Given this list of marker genes NR5A2, TAF4, FANCG, DMC1, NPPC, INHA, ZNF830, VGF, SOD1, LSM14B, EIF2B4, MMP19 (matrix metallopeptidase 19), FSHB (NCBI Gene Id 2488), FOXL2, BMPR1B, UBE3A, FOXO3 (forkhead box O3), SMAD4, ATM, GPR149, CGA, ZP3, BCL2, SCAPER, UMODL1, EIF2B5, ANG, EREG, LFNG, CTNNA1, AMH, FANCE, CEBPB, MSH4 (mutS homolog 4), FOXC1, IMMP2L, SPO11, MMP14, GNRH1, INHBB, KIT, KDR, ESR1, TNFAIP6, MMP2, FSHR (NCBI Gene Id 4959), GAS2, INHBA, PTX3, RAC1, PCYT1B, ZFY (zinc finger protein Y-linked), LHCGR, DMRTA1, HYAL3 (NCBI Gene Id 8372), KITLG, BAX, EIF2B2, BCL2L1, BCAS2, NPR2, VEGFA, here is a description of the gene set: The process whose specific outcome is the progression of the ovarian follicle over time, from its formation to the mature structure. studied in species Homo sapiens Human Gene Set: GOBP_OVARIAN_FOLLICLE_DEVELOPMENT